Given this list of marker genes Pik3r1, Nrg1, Erbb2, Nrg2, Erbb3, Cdk5, here is a description of the gene set: studied in species Mus musculus Mouse Gene Set: GOMF_ERBB_3_CLASS_RECEPTOR_BINDING Binding to the protein-tyrosine kinase receptor ErbB-3/HER3.